Given this list of marker genes DHFR, KIF23, UBE2T, LRRC8A, BORA, ANKRD39, EMG1, OAT, PCYT2 (NCBI Gene Id 5833), LCP1, PANK1 (NCBI Gene Id 53354), RUVBL1, TMEM25, PITPNB, MPHOSPH9, SERP1, YWHAQ, MRTO4, CDC25A, UBTF, RPP14, CCT4, SREBF2, NDUFAF2, MDC1, KBTBD8, GEMIN6, POMGNT1, SLC7A1, RAP1A, FH, PAQR3, CXCL3, FUS, SEC61A1, NIP7 (nucleolar pre-rRNA processing protein NIP7), LAMTOR3, PICALM, MXD4, BLVRA, LIG1, FANCL, HAUS3, PTP4A3, WNT5A, DHRS13, RAD54L, FYTTD1, CEP152, NUDT15, RSL24D1, CFDP1, DDHD2 (DDHD domain containing 2, NCBI Gene Id 23259), TSFM (Ts translation elongation factor, mitochondrial), TCP1 (NCBI Gene Id 6950), H2AZ1, AATF, COL5A1, ORC6, EIF3G, ZNF627, WLS, GPSM1, TIPIN, RRS1, CDR2 (cerebellar degeneration related protein 2), PPM1D, SUCLG1, SLC27A5, LAIR1, HERPUD1, PHLDA1, SMN1, HNRNPA3, LYNX1, SVIL, TNF, DKC1, EID1, GLRB, MYBPC3, NAP1L2, DFFB, PRXL2C (peroxiredoxin like 2C), FSHB, FNTB, SAMM50, MYO1E, EPB41L4B, LSM6, MAP3K20, HPRT1, ZNF330, BUB3, PGM2L1, MRPL50, HIRA, RGS11, PBK, HDAC3, FAM217B, UGGT1, RANBP1, SFPQ, NFATC2, TDP1, MTAP, IL23A, SLC12A6, NUP37, MANF, WDR46, NUDT4, ARL2BP, PLEK, SLC1A5, SYPL1, HINT1, DARS1, FERRY3, HELLS, RLIG1 (RNA 5'-phosphate and 3'-OH ligase 1), NAT10, SLC16A1, TMX4 (thioredoxin related transmembrane protein 4), AKR7A2, DNAJB8, CLEC5A, IL1R1, PTGES3, LMNA (NCBI Gene Id 7816), LPIN3, CALU, EEF1E1, UTP18 (NCBI Gene Id 51096), P4HB, MYO1D, WDR55, YEATS4, PA2G4, TAF1A, WDR90, LARP7, RHOJ, NNT, MYO19, MPHOSPH6, RRP9, CCDC115, MAGOH, UBTD2, GCSH, FAM13B, MLH1, MPHOSPH10, IRF4, PHB2, DPY30, BRWD1, VRK1, COTL1, SLC20A1, ATP13A3, PUM3, C19orf48P, RINT1, HGF, ZNF692, GLRX5 (glutaredoxin 5), CHTF8, HPF1, NUP188 (nucleoporin 188), SGO2 (shugoshin 2), FUT4, PCNX4, SQLE, PIGX, RRP15, CAD, ARPC4, FIGNL1, SPX (spexin hormone), NAP1L1, SLC7A5, RNF150, MCM5, PSMG2, SMARCA5, GSN, RAD17, CLSTN1, POLD2, SRSF9, CCT8, SLC4A3, INTS13, NDUFV2, NOP2, DEPDC1, EXOSC7, here is a description of the gene set: Human Gene Set: GSE22432_MULTIPOTENT_PROGENITOR_VS_CDC_DN studied in species Homo sapiens Dendritic cells (DCs) in lymphoid tissue comprise conventional DCs (cDCs) and plasmacytoid DCs (pDCs) that develop from common DC progenitors (CDPs). CDPs are Flt3+c-kitintM-CSFR+ and reside in bone marrow. Here we describe a two-step culture system that recapitulates DC development from c-kithiFlt3-/lo multipotent progenitors (MPPs) into CDPs and further into cDC and pDC subsets. MPPs and CDPs are amplified in vitro with Flt3 ligand, stem cell factor, hyper-IL-6 and insulin- like growth factor-1. The four-factor cocktail readily induces self-renewal of MPPs and their progression into CDPs and has no self-renewal activity on CDPs. The amplified CDPs respond to all known DC poietins and generate all lymphoid tissue DCs in vivo and in vitro. Additionally, in vitro CDPs recapitulate the cell surface marker and gene expression profile of in vivo CDPs and possess a DC-primed transcription profile. Transforming growth factor-β1 (TGF-β1) impacts on CDPs and directs their differentiation towards cDCs. Genome-wide gene expression profiling of TGF-β1-induced genes identified transcription factors, such as interferon regulatory factor-4 (IRF-4) and RelB, that are implicated as instructive factors for cDC subset specification. TGF-β1 also induced the transcription factor inhibitor of differentiation/DNA binding 2 (Id2) that suppresses pDC development. Thus, TGF-β1 directs CDP differentiation into cDC by inducing both cDC instructive factors and pDC inhibitory factors. from publication Felker P, Seré K, Lin Q, Becker C, Hristov M, Hieronymus T, Zenke M (PMID 20881193) Genes down-regulated in amplified multipotent progenitors versus common dendritic cells.